The following is a description of a gene set: Human Gene Set: MCGOWAN_RSP6_TARGETS_UP studied in species Mus musculus Mutations in genes encoding ribosomal proteins cause the Minute phenotype in Drosophila and mice, and Diamond-Blackfan syndrome in humans. Here we report two mouse dark skin (Dsk) loci caused by mutations in Rps19 (ribosomal protein S19) and Rps20 (ribosomal protein S20). We identify a common pathophysiologic program in which p53 stabilization stimulates Kit ligand expression, and, consequently, epidermal melanocytosis via a paracrine mechanism. Accumulation of p53 also causes reduced body size and erythrocyte count. These results provide a mechanistic explanation for the diverse collection of phenotypes that accompany reduced dosage of genes encoding ribosomal proteins, and have implications for understanding normal human variation and human disease. Genes up-regulated by hemizygotic cre-lox knockout of RSP6 in keratinocytes. from publication McGowan KA, Li JZ, Park CY, Beaudry V, Tabor HK, Sabnis AJ, Zhang W, Fuchs H, de Angelis MH, Myers RM, Attardi LD, Barsh GS (PMID 18641651), and this is the list of marker genes: GLRX3, SYT4, PMEL, SLC45A2, MGMT, EPHX1, NNT, GPNMB, CYP4F8, DDIT4L, TRPM1, SOX10, MDM2, PTGDS (NCBI Gene Id 5730), PCOLCE2, ZDHHC3, AAAS, C2orf80, PTP4A3, EDNRB